Given this list of marker genes Rpl38, Mrps33, Mrpl24, Mrpl1, Mrpl35, Mrps9, Eif3d, Eif5b, Mrpl43, Rpl19, Rpl7a, Rpl34, Mrpl40 (mitochondrial ribosomal protein L40), Mrpl37, Mrps18b, Rpl36a-ps1, Mrpl15, Eef1b2, Mrpl27, Rpl27a (ribosomal protein L27A), Eif4g1, Eef1g, Eif4e, Rplp2, Eif3j2, Mrps18c, Rps27a, Eif3a, Eif3h, Fau, Rpl24 (NCBI Gene Id 68193), Rpl18, Gfm2, Mrrf, Rpl36 (ribosomal protein L36), Rps9, Rpl27, Oxa1l, Eral1, Rps19, Mrpl46, Rpl35rt, Eif4b, Mrps10, Mrpl21, Rpl30, Ppa1, Rpl15, Mrpl19, Mrpl36, Eif3b, Rpl23a, Mrpl57, Rpl31, Rps6, Srp9, Mrps25, Rps28, Mrpl18, Dap3, Chchd1, Rpl11, Rpl36al, Rpl4, Apeh, Srp19 (signal recognition particle 19), Rps24, Mrpl51, Rpl18a, Gspt2, Mrpl48, Mrps2, Mrpl22, Rpl14, Uba52, Pabpc1, Rplp0 (NCBI Gene Id 64336), Mrps5, Mrpl34, N6amt1, Rps7, Rps13, Mrpl14, Rpl39l, Rpl35, Eif2s2, Eif2b5, Etf1, Mrps12, Rpl26, Mrpl49, Gm6525, Rpl22, Mrps31, Rps15, Mrpl16, Eif3m, Rps20, Mrpl44, Rps26, Ppa2, Eef1d, Eif3k, Srp72, Mrpl47, Rpl32, Rpl37a, Eif2b1, Mrpl11, Mrps30, Rps15a (NCBI Gene Id 319296), Rpl36a, Mrps7, Mrps16, Mrpl17, Eif3c, Eef1a1, Rpl3, Rpl37, Mrpl13, Eif1ax, Rpl10, Rps3a1, Mrpl32, Eif3e, Uba52rt, Rpl5, Rpl7, Mrpl39 (NCBI Gene Id 54134), Mrps28, Rpl13a, Mrpl58, Rpl39, Mrpl45, Mrps22, Rps3, Eif5, Eif2s1, Eif3g, Rpl10l, Mrpl23, Rps29, Trmt112, Mrpl12, Mrps15, Gadd45gip1, Rpl8, Mrps36, Mrps14, Rpl28, Rps2, Rps11 (ribosomal protein S11), Ptcd3, Mrpl4, Rpl29, Rps12, Eef2, Rpl17, Rpl10-ps3, Eif4ebp1, Srp54a, Rps21, Rps16, Mrpl52, Srp54b, Srp68, Mrpl38, Rps27rt, Rps25, Rpl3l, Rps27l, Mrpl42, Mrps21, Gspt1, Rps8 (ribosomal protein S8), Mrpl41, Rpl12, Mrpl20, Mrps26, Mrps18a, Eif3f, Rplp1, Rpl35a, Rpl21, Mrps27, Mrps11, Rpl23, Mrps34, Eif4a1, Rps4x, Mrpl2, Rps14, Rps5 (NCBI Gene Id 20103), Mtrf1l, Gfm1, Rps18, Mrpl28, Mrpl3, Eif2s3x, Mrps6, Eif3l, Mrpl55, Mrpl30, Mrps24, Rpl6, Aurkaip1, Mrps23, Eif3i, Mrpl50, Rpl22l1, Rpsa, Rpl13, Eif4h, Rps10, Mrpl33, Mrps17, Eif4a2, Eif2b3, Mrpl9, Mrps35, Eif2b2, Mrpl53, Mrpl10, Rpl9, Rps23, Srp14, Eif2b4, Rps17, Eif3j1, Mrpl54, Rps27, here is a description of the gene set: studied in species Mus musculus Mouse Gene Set: REACTOME_TRANSLATION Translation